The following is a description of a gene set: A noninflammatory, progressive occlusion of the intracranial carotid arteries owing to the formation of netlike collateral arteries arising from the circle of Willis. species: Homo sapiens Human Gene Set: HP_MOYAMOYA_PHENOMENON Moyamoya phenomenon, and this is the list of marker genes: RNASEH2A, RNU7-1, RNASEH2B, ADAR, LSM11, PCNT, TREX1, SAMHD1, IFIH1, GUCY1A1, BRCC3, RNASEH2C, ACTA2, NFIA, RNF213